Given this list of marker genes KIAA0232, LACC1, TMEM59, GEMIN2, PABPC4, COL6A3, WNK3, HDGF, ZBTB20, KLHL28, MTRR, KICS2, ZFHX4, KIAA0040, POM121C, ZFHX3, IQCK, YES1, ALKBH6, ZSWIM6, RORA, GDNF, HOOK3, MYO5A, KLHL15, ZNF365, ZNF544 (NCBI Gene Id 27300), BPNT2, RNF2, MYCT1, TENT4B, LPXN, PALM2AKAP2, ZDHHC15, KCTD21, SEC62, SLC25A6, GK5, AAK1, ARHGAP44, CDX2, SLC6A11, SNAPC1, DNAJB14, GEM, DNMT3B, ETNK1, DGKH, SLC1A2, MFSD8, ZNF770 (NCBI Gene Id 54989), TCIM, BTF3L4, SMAD4, TIGD3, PTN, CADM1, PROX1, SLC30A1, SRA1, CREB5, RBPJ, FAM53C, CCDC82, POU2F1 (POU class 2 homeobox 1), CCDC50, MAP3K2, PLA2G7, BDKRB2, CCNG1, ZNF277, NRSN1, INO80D, TGFBR1, CDC42, CHTF8, DCBLD2, CBX5, OTULIN, RICTOR, ADAM30, TMEM132D, TRABD2B, THSD7B, SUMO2, LINC03034, SLC7A14, RP1, CELF6 (NCBI Gene Id 60677), PPM1L, MED26, ARHGAP5, ZNF547, USP49, GATAD2A, SH3D19, GPATCH2, MEF2A, ACSL4, ENTPD3, ACVR2B, MYO5B, RWDD2B, SPRY1, HYCC2, PPP1CB, PPP3CC, TCEA1, GLRX3, QSER1, FRMD3, RPP30, SS18, ISL1, UBXN7, BRWD3, JCAD, ANGEL1, PLAGL2, RASGEF1A, PERP, COG6, ANKRD50, ZFP28 (NCBI Gene Id 57588), AGO3, ALKBH5, ATP6V1G1, MRPL10, RNF44, UNG, USP31, FGFBP3 (fibroblast growth factor binding protein 3), BBX, SLC10A7, MPZL2, PPP1R3A, RBM18, DLG3, ZMYM4, ATXN7L3B, ZNF518A (zinc finger protein 518A), PPP1R12B, ATP2B4, TIAM1, XRN1, ZNF670, EIF4A3, LHX9, PIGK (phosphatidylinositol glycan anchor biosynthesis class K), AMMECR1, SNX27, ANOS1, TM9SF4, PMPCB, CAMKMT, NAPG, PTBP3, TMEM200B, PDE1C, ACVR1C, PDPR, ELAVL2, VCL, OSBPL1A, BTN3A3, CD48, MED12L, SLITRK2, RCC2, PRLR, ARIH1, HDGFL3, FNBP1L, CRTAP, PPP1R2, CCDC186, CDH1, CLASP2, GPR180, KMT2D, POU5F2 (POU domain class 5, transcription factor 2), GPC6, MKRN1, ZFP69, RAG1, PGM2L1, EEA1, CADM2, ARFGEF3, NTM, GSPT1, KDSR, RBMX, MTPAP, EMX2, PLA2G4D, RSPO2, WDR43, TRIP12, PLBD1, GJA1, TBL1XR1, SPICE1, ST6GALNAC3, FN1, ZBTB18, FNDC3A, UBE3C, ANXA9 (NCBI Gene Id 8416), HOXC9, TXLNB, DIPK1A, EPM2AIP1, PCM1, CALM1, NFIB, ELAPOR2 (NCBI Gene Id 222223), TSPAN7, FSD2, RBMS3, FSBP, RIMOC1, FLRT1, ZNF492, CD300E, RIMKLB, DSCAM, MEF2C (myocyte enhancer factor 2C), PTPRD, LATS1, ROCK2, MICOS10, PRR23B (NCBI Gene Id 389151), ZBTB39 (NCBI Gene Id 9880), TBCEL, MIER1 (NCBI Gene Id 57708), CNOT7, EXOC5, MED30, ZMYM6, ATG10, MSI2, LYST, LMBRD2, RAD54B, DNAH12, HAUS5, ZNF703, THSD7A, MCPH1, ZC3H6, GSK3B, SLITRK1, EYA3, POM121, PAPPA, DPPA5, PCDH19, CLRN3, DCLK1, DOCK3, PAK1IP1, PPIL1, FKBP7, CEACAM7, SRBD1 (S1 RNA binding domain 1), ABI2, SRSF2 (NCBI Gene Id 6427), PBX2, AGER, LATS2, VTI1A, FGA, NR1H3, MAGI3, XXYLT1, PGR, ZNF3, USP38, SMIM21, MARCHF6, GP1BA, DIRAS3, CCDC97, KRTAP4-1, TM9SF3, CFAP53, CTPS2, TXNL4B, DTNA, IKZF3, NEK9, PTPN14, RNASEL, THRB, FZD3, LCORL, SNRPF, CCNT1, CRIPTO (NCBI Gene Id 6997), PTPRT, ZNF695, PCGF3, ENAM, ZMAT3, MCM8, MTCL3, ZNF606, PCNT, ZMYM2, CD164, HNRNPA2B1, TRNP1, ZNHIT6, STAM2, TMCO3, GAB1, LYPD6, KLHL31, AUTS2, SET, GRM6, ENPP5, BAZ2A, RALGAPA1, ZNF124, SMIM12, HDDC2, DLG2, YWHAZ, EPHA3, APOOL, SEPTIN11, VANGL2, ATP11C, GNAQ, ZSCAN30, KANSL1, RPL22L1, DICER1, CDV3, MIEF1, SLC39A12, SLC31A2, AK9, YWHAG, ASTN1, F2RL2, PNRC1, NINL (NCBI Gene Id 80250), DR1, MAML2, ELK4, MRAS, SLC25A38 (NCBI Gene Id 54977), ZKSCAN3, PIGN, PTPRJ, COL19A1, ZNRF1, CREBL2, ARFIP2, XYLT1, FBXO4, FAM199X, DENND6A, ROR1, GIGYF2, PPP6C, TGIF2, NFIA, LSM8, WIPF1, LBH, SPOCK3, DUSP19, NUFIP2, DACH1, FCHSD1, MS4A4A, RABGEF1, CACNA1C, HCCS, CTNNA3, GTDC1, ZMPSTE24, HAO1, ENY2, KPNA3, GAS7, PHACTR2, TRIM71, CHD2, INTS6, SLC5A3, MEX3C, BACE1, NEMF, SGIP1, IL18BP, RC3H1, LCMT2, KMO, RIC8B, KLF12, GRM5, TMEM67, SLC9A2, CTNNA1 (catenin alpha 1), TOMM20, TMEM25, CHRM2, DUSP4, SLC12A2, PRIM2, CAMK2D, CDH3, KCNE4, TTPAL, CADM3, ZNRF3, TFDP2, LARS1, AFF1, FAXC, LRP6, SINHCAF, COLGALT2, SHOC2, KIF16B, BEST3, ZFX, GABRA5, SHB, ZFP91, TNPO1, ABTB3, CMTM4, EFNA5, TLK2, TMEM65, TMPRSS15 (NCBI Gene Id 5651), MAST4, ZDHHC18, CNNM3, TMEM127, UBE4B, NCAPD3, STAT1, AMER1, MASP1, PCNX1, ANXA2R, SHTN1, ANKRD6, SAMD4A, REP15 (RAB15 effector protein), NPTX2, SHISAL1, TRPS1, RBM14, NFAT5, TRIO, POU3F4, MOB3B, PRKAB2, CCNJ, TULP4, KATNAL1, PAPOLA, VAPB, CORO2B, CASTOR2, here is a description of the gene set: Genes predicted to be targets of miRBase v22 microRNA hsa-miR-4668-5p in miRDB v6.0 with MirTarget v4 prediction scores > 80 (high confidence targets). from publication Chen Y, Wang X (PMID 31504780) species: Homo sapiens Human Gene Set: MIR4668_5P